Given this list of marker genes Bcl2, Cfc1, Onecut1, Lipa, Rcbtb2, Ppp2r3c, Rbm15, Kmt2a, Nfkb2 (nuclear factor of kappa light polypeptide gene enhancer in B cells 2, p49/p100), Fgf10, Dicer1, Polb, Flt3, Tlx1, Rc3h1, Hoxb4, Traf3ip2, Pbx1, Fam210b, Epb42, Samd9l, Abl1 (NCBI Gene Id 98922), Barx1, Cdkn2b, Myb, Flvcr1, Adam17, Coa5, Nfkbiz, Tcf21, Pkn1, Cacnb4, Ahr, Jarid2, Bcl2l11, Prkdc, Slc40a1, Sco1, Nkx3-2, Nkx2-5, Cdh17, Pcid2, Fas, Bcl3, Cited2, Fadd (NCBI Gene Id 14082), Pitx2, Ripk3, Rc3h2, Ctc1, Tet2, Nkx2-3, here is a description of the gene set: Mouse Gene Set: GOBP_SPLEEN_DEVELOPMENT studied in species Mus musculus The process whose specific outcome is the progression of the spleen over time, from its formation to the mature structure. The spleen is a large vascular lymphatic organ composed of white and red pulp, involved both in hemopoietic and immune system functions.